Given this list of marker genes RFXAP, FTH1, B2M, ALB, TF (NCBI Gene Id 7018), RFXANK (NCBI Gene Id 8625), CIITA, RFX5, here is a description of the gene set: A deviation from the normal concentration of beta globulin. The beta globulins are a group of globular (globe-shaped) proteins in blood. Abnormal circulating beta globulin level Human Gene Set: HP_ABNORMAL_CIRCULATING_BETA_GLOBULIN_LEVEL species: Homo sapiens